The following is a description of a gene set: Binding to fucose, the pentose 6-deoxygalactose. Human Gene Set: GOMF_FUCOSE_BINDING studied in species Homo sapiens, and this is the list of marker genes: CLEC10A, ACR, ASGR1, COLEC11, CLEC17A, ASGR2, SELP, FUOM